Given this list of marker genes GLB1, GLB1L2, GLB1L3, GLB1L, GBA3, here is a description of the gene set: Human Gene Set: GOMF_BETA_GALACTOSIDASE_ACTIVITY species: Homo sapiens Catalysis of the hydrolysis of terminal, non-reducing beta-D-galactose residues in beta-D-galactosides.